Given this list of marker genes Bbs2, Gnas, Stc2, Lgmn, Ankrd26, Alms1, Ptch1, Atxn2, Adrb1, Plac8, Socs2, Gdf15, Adrb2, Fxn, Adrb3, H19, Rai1, here is a description of the gene set: Mouse Gene Set: GOBP_NEGATIVE_REGULATION_OF_MULTICELLULAR_ORGANISM_GROWTH species: Mus musculus Any process that stops, prevents, or reduces the frequency, rate or extent of growth of an organism to reach its usual body size.